Given this list of marker genes H2AC6, H2BC4, H2BC9, H2BC14, H2BC7, H4C3, H4C5, H2AC18, H2AC8 (NCBI Gene Id 3012), NOBOX, AGO2 (NCBI Gene Id 286109), SRPK1, TUT4, H2BC10, H4C4, H2AZ2, CNOT6, TUT7, KDM5A, H3C15, TEAD4, PABPC1, DPPA4, H2AC7, PABPN1L, H4C14, H2AC19, DPPA3, H2BC5, H2BC3, H2BC6, H3C7, H2AJ, PAIP2, H3C1, FGF8, CNOT10, AICDA, LEUTX, CNOT11, H3C3, H2BC12, DICER1, H3C4, DUX4, H3-3B, H3C10, KDM4E, H2BC8, UNG, EP300, BTG4, H2AX, STPG4, H2BC15, HIRA, TPRX2 (tetrapeptide repeat homeobox 2), ZSCAN4 (NCBI Gene Id 201516), CNOT8, H3C12, EIF4A1, PADI6, CNOT9, KDM5B, H4C16, CNOT6L, TET3, NPM2, H2BC17, PRM2, H3C2, H4C2, ZFP36L2, KDM6B, UHRF1, ELOC, H3-3A, H2BC1, EIF4B, EIF4A2, H2BC12L, H2AC20 (NCBI Gene Id 8338), H4C13, H2AC4, H3C11, CNOT3, H4C11, H2AC14, H3C6, EIF4E, ZP2, CNOT4, YAP1, H4C6, CNOT7, H2BC13, H3C13, PRM1, CREBBP, H4C12, H2BC21, H4C1, H4C15, TP53, H2BC11, PABPN1, CNOT2, H3C14 (H3 clustered histone 14), KDM6A, H1-8, EIF4A3, TNKS1BP1, RPS2, H4C9, POLR2D, H2AB1, EIF4G1, DUXB (NCBI Gene Id 100033411), DPPA2, PAIP1, H4C8, H2BC26, TPRX1, CNOT1, METTL23, DIS3L2, H3C8, DUXA, here is a description of the gene set: Human Gene Set: REACTOME_MATERNAL_TO_ZYGOTIC_TRANSITION_MZT Maternal to zygotic transition (MZT) species: Homo sapiens